Given this list of marker genes LRP2, DMRTA2, METRN, MAP2K1, ID4, MME, PRKCI, RUFY3, CDKL3, MIR222, CUX1, GPRASP3, CAPRIN2, TNFRSF1B, SRF, SERPINF1, KHDC3L, PLXNB3, ASPM, PTN, GLI3, PPP1CC, MIR221, IL34, TRPC5, NKX2-2, SMARCD3, NUMBL, ADNP, WDR62 (NCBI Gene Id 4181), FXR1, NRP1, BMPR2, NAP1L1, NIN, TRPV2, OLIG2, XRCC5, EPHA4, STAU2, SERPINE2, IL6, CAMK2B, HDAC6, MECP2, ZFYVE27, TENM4, CUL7 (NCBI Gene Id 9820), RAB21, OBSL1, ZNF335, SS18L1, ID2, LIMK1, RASSF10, DHX36, ZEB2, IL1B, BAIAP2 (NCBI Gene Id 10458), ITGB1, MACF1, VEGFA, EFNA5, NKX6-1, SNW1, DCT, EPHB2, CTNNB1, E2F1, EEF2K, MTOR, FOXG1, TIAM1, PLXNB1, GRM5, SOX10, FZD3, TIAM2, FZD4, SEMA5A, SPEN, TWF2, CRABP2, NUMB, RELN, ATXN1, CXCR4, WNT2, DBN1, SKIL, SEMA4D, KRAS, RNF112, HES1, PARP6, SLC7A5, OTP, RND2, DAG1, MAP1B, NKX6-2, CUX2, TRAK1, KIT, WNT3 (Wnt family member 3), GPER1, EGR2, VEGFC, MYB, XRCC2, IFNG, WNT3A, AMIGO1, TSPO, FN1, PAK1, NRDC, TBC1D24, PTPRD, BCL11A, PTPRZ1, MIR125B1, BMP2, DSCAM, DISC1 (NCBI Gene Id 80138), CDKL5, LIF, ROBO2, MYRF, UFL1, ARMCX5-GPRASP2, SHANK3, LRP8, CX3CL1, SHTN1, ANKRD27, BDNF, ITPKA, NTRK3, LYN, SOX11, FXR2, RGS14, MAN2A1, PAX6, HDAC1, MAG, TRIM32, CDON, SLITRK1, GOLGA4, CLCN2, NEFL, ETV5, SPINT1, MIR142, ADCY10, LTA, PLAG1, GDI1, CLCF1, MAPT, SMURF1, RHEB, SHH, CX3CR1, KDM1A, CXCL12, TP73, PAFAH1B1, HDAC2, OPRM1, ANAPC2, FGF2, NPTN, ZNF365, SEMA7A, POU4F2, ZNF488, TNF, CAPRIN1, SLC30A1, SHOX2, PLXND1, MEGF8, TGM2, STK25, PLXNC1, SOX8, NOTCH1, ELL3, RELA, QKI, BRAF, IST1, PLXNB2, HAP1, L1CAM, IL6ST, MAP6, SRRT, TNFRSF12A, DICER1 (NCBI Gene Id 4333), STK11, NTRK2, SLIT2, MAP2K2, HIF1A, ISLR2, CDH4, NR2E1 (NCBI Gene Id 7101), NEURL1, SMO, TTBK1, ASCL1, GSX2, BIN1, MAP3K13, LPAR3, ROBO1, GFAP, CHODL, DRD2, MDK, PRMT5, FBXW8, PRKCH, IL1RAPL1, LIG4, NTN1, FMR1, NGF, TGFB1, here is a description of the gene set: species: Homo sapiens Any process that activates or increases the frequency, rate or extent of neurogenesis, the generation of cells within the nervous system. Human Gene Set: GOBP_POSITIVE_REGULATION_OF_NEUROGENESIS